The following is a description of a gene set: Human Gene Set: GOBP_POSITIVE_REGULATION_OF_ANTIGEN_RECEPTOR_MEDIATED_SIGNALING_PATHWAY Any process that activates or increases the frequency, rate or extent of signaling pathways initiated by the cross-linking of an antigen receptor on a B- or T cell. species: Homo sapiens, and this is the list of marker genes: FOXP1, CD81, PRKCH, TESPA1, LCK (NCBI Gene Id 95387), LIPA, PRKD2, CD226, TRAT1, RAB29, NECTIN2, CYLD, IKBKG (inhibitor of nuclear factor kappa B kinase regulatory subunit gamma), KCNN4, SLC39A10, STAP1, PTPRC, MIR18A, CCR7, UBR2, RELA, CARD11, RPS3, BCL10, NFAM1 (NFAT activating protein with ITAM motif 1), CMTM3, ADA, MIR19A